The following is a description of a gene set: from publication Jeffrey KL, Brummer T, Rolph MS, Liu SM, Callejas NA, Grumont RJ, Gillieron C, Mackay F, Grey S, Camps M, Rommel C, Gerondakis SD, Mackay CR (PMID 16474395) Genes down-regulated in comparison of central memory CD4 T cells versus Th2 cells. Human Gene Set: GSE3982_CENT_MEMORY_CD4_TCELL_VS_TH2_DN In the present study we used Affymetrix oligonucleotide microarrays to produce gene transcription profiles for the major leukocyte types in humans. This comprehensive dataset enabled us to not only establish which genes were expressed in each leukocyte type, but also which genes were expressed in each subset after activation. The used of a comprehensive dataset of gene profiles from all the major human leukocyte subsets enabled a novel and powerful means for identification of genes associated with single leukocyte subsets, or different immune paradigms. studied in species Homo sapiens, and this is the list of marker genes: UCP1, CTNNA1, TUBB6, SPRED2 (sprouty related EVH1 domain containing 2), ETHE1, ACO2, CDK1, CNOT7, NT5C, TFB2M, EXOSC9, LRRN3, GOLT1B, VDAC2, MTHFD2, PTTG1, DSG2, PYCR1, NFE2L3, DCTPP1, BRCA1, LARP4, LBHD1, H2AC4, PSMD3, TPRKB, MTCH2, DLGAP5, ATP2A2, NASP, CSF1, WBP4, UBE2S, ESF1, SHMT2, HDDC2, CFI, ESPL1, HSD17B10, SMC4, PEMT, TSPAN3, MXRA7, PHLDA1, KIFC1, GSTP1, AURKA (aurora kinase A), C1orf216, YBX1 (Y-box binding protein 1), GSS, MRPL23 (mitochondrial ribosomal protein L23), NDUFS7, GPSM2, SEC23B, POLE2, DUSP6, TMEM208, H2BC9, TRAPPC2L, MCUR1, TJP2, DCTN6, AK2, PAK1IP1, CHKA, GRPEL1, MT2A, CENPF, PTGES2, ATP5MC1, CCNB2, TULP2, CSNK2A1, TMEM177, MRPL39, MT1G, HSPE1, TKT, BLTP3B, SLC39A14, ARPC5L, MICAL2, EGR1, YIF1A, NCBP1, GGH, GLRX3, MRPL12, SLC25A6, PIP5K1B, TIMELESS, ASPA, MRPS34, RPA3, SRF, XRCC3, CDC123, ALDOC, PSMA2, PSMB2, TIPIN, TOP2A, CXCR6, NFIL3, GMPPB, CTPS1, ALDH3A2, PSMD7, COX7A2, CDC45, KIF2A, CA2, MRPS11, KCNK5, VDAC1, PLA2G2A, NUDT21, GGCT, RFC2, MYB, TIMM8B, AOAH, COQ3, FOXM1, PRF1, POGLUT2, CD63, OXCT1, RBM14, NCAPG (NCBI Gene Id 64151), UQCRFS1, NDUFS6, C19orf53, RTCB, SEC61G, TTK, CAVIN3, RNASEH2A, HEATR3, MKLN1, TRIB3, ATP5F1B, TRIP13, MCM3, DPAGT1, ADGRA3, LAIR2, SLC35F5, ACOT7, ENO1, SNRPB, ATP1A3, FANCI, EIF6, PPP1R3C, WAPL, GRB2, RAB11FIP1, RAB38, STT3A, GFUS, NR1H2, MAOA, CHCHD2, PALLD, LGALS1, ETNK1, RRP7A, RMDN1 (regulator of microtubule dynamics 1), CD200, POLQ, USP22, SSRP1, GSTZ1, FSD1, TUBB, AHI1, EMC8, RRM2, TIMM13, TYMS, CDK2AP1, BIRC5, DDX41, WARS2, JADE3, BTG3, KNOP1, KCTD5, FGD6, FASN, IL12RB2, PDIA4, PRDX3, MED21, GMNN, CCL1, BLM, GSTT1, GMEB1